Given this list of marker genes Nbn, Ercc1, Ercc4 (excision repair cross-complementing rodent repair deficiency, complementation group 4), Xrcc1, Smg6, Atm, Terf2, Xrcc4, Rad50, here is a description of the gene set: Any process that stops, prevents or reduces the frequency, rate or extent of telomere capping. species: Mus musculus Mouse Gene Set: GOBP_NEGATIVE_REGULATION_OF_TELOMERE_CAPPING